Given this list of marker genes ELOA, CCNT2, NELFB, CDK9, POLR2L, POLR2K, POLR2A, CCNK, SUPT16H, ELL, NELFE, ELOB, TCEA1, NELFA, CCNT1, GTF2F2, GTF2F1, POLR2J, POLR2E, SSRP1, POLR2F, ELOC, ELOA2, NELFCD, POLR2I, POLR2G, POLR2H, POLR2D, SUPT5H, CTDP1, POLR2B, POLR2C, SUPT4H1, here is a description of the gene set: studied in species Homo sapiens RNA Pol II arrest is believed to be a result of irreversible backsliding of the enzyme by ~7-14 nucleotides. TFIIS reactivates arrested RNA Pol II by promoting the excision of nascent transcript ~7-14 nucleotides upstream of the 3' end. Reactome Pathway: HIV elongation arrest and recovery part of: Transcription of the HIV genome